Given this list of marker genes FRAS1 (Fraser extracellular matrix complex subunit 1), GRIP1, TWIST2, FREM1, FREM2, MAB21L2, here is a description of the gene set: Cryptophthalmos is a condition of total absence of eyelids and the skin of forehead is continuous with that of cheek, in which the eyeball is completely concealed by the skin, which is stretched over the orbital cavity. Human Gene Set: HP_CRYPTOPHTHALMOS studied in species Homo sapiens Cryptophthalmos